The following is a description of a gene set: Synaptic vesicle pathway studied in species Homo sapiens Human Gene Set: WP_SYNAPTIC_VESICLE_PATHWAY, and this is the list of marker genes: STXBP1, SLC6A4, AP2M1, DNM3, SNAP25, ATP1A2, CACNA1A, SYN3, SLC25A4, SLC17A7, NAPA, SLC22A3, CLTCL1, UNC13B, SLC17A8, STX1A, AP2A1, CPLX2, VAMP2, UNC13C, SLC32A1, DNM2, SYN2, NSF, RAB3A, CPLX1, SLC18A3, STX3 (syntaxin 3), STX2, SYT1, CPLX3, RIMS1, SLC38A1, DNM1, SLC18A2, SLC18A1, DNM1L, SYN1, SYP, CLN8, CLTC, UNC13A, PARK7, AP2A2, AP2B1, AP2S1, CACNA1B, STX1B (syntaxin 1B), SLC17A6, SLC1A3, CLTA